Given this list of marker genes Cdc20, Camk2b, Anapc2, Neurl1a, Hnrnpk, Neurod2, Dab2ip, Adgrl1, Reln, Nrxn1, here is a description of the gene set: species: Mus musculus Mouse Gene Set: GOBP_POSITIVE_REGULATION_OF_SYNAPSE_MATURATION Any process that increases the extent of synapse maturation, the process that organizes a synapse so that it attains its fully functional state.